Given this list of marker genes Ikbkg, Il31ra, Il2, Il10ra, Traf6, Usp18, Nfkb1, Psmb3, Pik3r2, Nod1, Hsp90b1, Psma6, Ubc, Dusp4, Il6, Smarca4, Il1rl2, Tab2, Yes1, Il34, Stx1a, Fyn, Lifr, Psmd3, Syk, Ripk2, Ebi3, Il12rb1, Peli1 (pellino 1), Map2k6, Nkiras1, Il36g, Canx, Il5ra, Psmc1, Il6ra, Tslp, Psma7, Il36rn, Lck, Ppp2r1b, Tab3 (TGF-beta activated kinase 1/MAP3K7 binding protein 3), Ptpn11, Peli2, Psmb5, Nlrc5, Ube2v1, Irak4, Sqstm1, Psma2, Il24, Snap25, Il1rn, Lrrc14, Il1rap, Il4ra, Uba52rt, Psma4, Il4, Cd4, Il7, Ptpn6, Socs3, Psmd2, H3c1, Il11ra1, Irak2, Irak3, Psmd11, Tyk2, Rps6ka3, Crkl, Stat3, Nfkbib, Il36b, Map2k4, Il22ra2, Il27, Mapk7, Il21r, Traf2, Mapkapk2 (NCBI Gene Id 98242), Rapgef1, Pik3ca, Stat2, Casp3, Crlf1, Csf1r, Psma3, Ppp2ca, N4bp1, Ctsg, Il3, Nkiras2, Il18r1, Psma5, Csf1, Shc1, Rela, Lif, H3c13, Mapk8, Ikbkb, Pik3cd, Il23a, Ppp2r1a, Mapkapk3, Map2k3, Tbk1, Inpp5d, Grb2, Gsdmd, Stat5a, Rps6ka5, Psmd1, Rps27a, Il22ra1, Creb1, Il20ra, Il15ra, Adrm1, Il1rapl1, H3c4, Il1f10, Tollip, Psmc6, Nlrx1, Dusp7, Map3k7, Casp8, Psmd8, Skp1, Atf2, Psmb7, Il1rl1, Psmd12, Socs1, Il13, Vamp2, S100b, Lyn, Psmd14, Csf2rb, Osmr, Psmd7, H3c15, Ubb, Psmb1, Tifa, Csf2, Il19, Fos, Il18rap, H3c6, Vav1, Il18bp, Fbxw11, H3c2, Map3k8, Ywhaz, Il31, Crk, Sdc1, H3c14, H3c3, Il2rg, Ifnl3, Rps6ka2, Irak1, Il20, Hmgb1, Sos2, Mapk10 (mitogen-activated protein kinase 10), Mapk1, Il12a, Irs2, P4hb, Il1b, Hck, Psma1, Il1r1, Stx4a, Psmd6, Chuk, Il1r2, Nod2, Jun, Il9, Ctf1, Ppp2r5d, Il11, Ifnl2, Il20rb, Il13ra2, Stat6, Mapk9, Il27ra, Mapk14, Il12b, Clcf1, Pik3r1, Il2ra, Rbx1, Ager, Nfkb2, Cul1, H3c8, Il21, Il18 (interleukin 18), Osm, Il16, Mapk11, Peli3, H3c10, Psmc5, Myd88, Tab1, Jak2, Sos1, Nfkbia, Pik3cb, Il12rb2, Atf1, Dusp3, Map2k7, H3c11, Vrk3, Il36a, Ppp2cb, Stat5b, Psmb4, Il13ra1, Alpk1, Ptprz1, Il9r (NCBI Gene Id 16199), Tnip2 (NCBI Gene Id 69105), Ifnlr1 (interferon lambda receptor 1), Inppl1, Uba52, Il6st, Ptk2b, Ube2n, App, Il22, Casp1, Rps6ka1, Brwd1, Usp14, Il5, Txlna, Dusp6, Csf2rb2, Stxbp2, Il15, Il10rb, Psmc2, Il10, Psmc3, Prkaca, Pik3r3, Cntf, Psmb6, Psmd13, Cbl, Il1a, Il7r, Il23r, Mapk3, Il2rb, Psmc4, Psmb2, Map3k3, Il33, Stx3, Socs5, H3c7, Cntfr, here is a description of the gene set: Mouse Gene Set: REACTOME_SIGNALING_BY_INTERLEUKINS Signaling by Interleukins species: Mus musculus